The following is a description of a gene set: studied in species Homo sapiens part of: Antimicrobial mechanism of IFN-stimulated genes Reactome Pathway: ISG15 antiviral mechanism Interferon-stimulated gene 15 (ISG15) is a member of the ubiquitin-like (Ubl) family. It is strongly induced upon exposure to type I Interferons (IFNs), viruses, bacterial LPS, and other stresses. Once released the mature ISG15 conjugates with an array of target proteins, a process termed ISGylation. ISGylation utilizes a mechanism similar to ubiquitination, requiring a three-step enzymatic cascade. UBE1L is the ISG15 E1 activating enzyme which specifically activates ISG15 at the expense of ATP. ISG15 is then transfered from E1 to the E2 conjugating enzyme UBCH8 and then to the target protein with the aid of an ISG15 E3 ligase, such as HERC5 and EFP. Hundreds of target proteins for ISGylation have been identified. Several proteins that are part of antiviral signaling pathways, such as RIG-I, MDA5, Mx1, PKR, filamin B, STAT1, IRF3 and JAK1, have been identified as targets for ISGylation. ISG15 also conjugates some viral proteins, inhibiting viral budding and release. ISGylation appears to act either by disrupting the activity of a target protein and/or by altering its localization within the cell., and this is the list of marker genes: NUP98 (nucleoporin 98 and 96 precursor), TRIM25, RIGI, MX2, EIF4G1, SEH1L, RPS27A, EIF4A1, UBE2N, STAT1, EIF4G3, FLNB, KPNA5, BECN1, NUP188, RAE1, ARIH1, KPNA7, NUP58 (NCBI Gene Id 9818), NUP133, NUP93, PIN1 (peptidylprolyl cis/trans isomerase, NIMA-interacting 1), NS, NUP85, NUP54, NUP210, NEDD4, JAK1, POM121, PPM1B, KPNB1, NUP160, KPNA2, IFIT1, NUP153, NUP35, ISG15, KPNA3, EIF2AK2, EIF4E (eukaryotic translation initiation factor 4E), MAPK3, NUP50, NDC1, UBB, NUP37, NUP62 (nucleoporin 62), NUP155, RANBP2, NUP205, USP18, HERC5, UBA52, NUP107, NUP42 (nucleoporin 42), POM121C, EIF4A3, NUP214, EIF4E2, KPNA4, UBE2L6, NUP43, AAAS, IRF3, KPNA1, EIF4G2, gag, EIF4E3, TPR, UBA7, MX1, UBC, SEC13, EIF4A2, PLCG1, NUP88, UBE2E1